Given this list of marker genes ALKBH2, here is a description of the gene set: part of: Reversal of alkylation damage by DNA dioxygenases species: Homo sapiens Reactome Pathway: ALKBH2 mediated reversal of alkylation damage AlkB is an E.coli alpha-ketoglutarate- and Fe(II)-dependent dioxygenase that oxidizes the relevant methyl groups and releases them as formaldehyde. Two human homologs of AlkB, ALKBH2 and ALKBH3, both remove 1-methyladenine (1-meA) and 3-methylcytosine (3-meC) from methylated polynucleotides in an alpha-ketoglutarate-dependent reaction. They act by direct damage reversal with the regeneration of the unsubstituted bases. E.coli AlkB and human ALKBH2 and ALKBH3 can also repair 1-ethyladenine (1-etA) residues in DNA with the release of acetaldehyde.